The following is a description of a gene set: Catalysis of a biochemical reaction in which one of the substrates is a glycoprotein. studied in species Homo sapiens Human Gene Set: GOMF_CATALYTIC_ACTIVITY_ACTING_ON_A_GLYCOPROTEIN, and this is the list of marker genes: MGAT5B, MGAT5, MGAT3, FUT8, B3GNT3, C1GALT1C1, B4GALT7, MGAT2, GCNT4 (NCBI Gene Id 51301), B4GALNT3, GCNT1, MGAT4A, ABO, MGAT4C, POMGNT1, MGAT4B, B3GALT6, C1GALT1, MGAT1, C1GALT1C1L, GCNT3 (glucosaminyl (N-acetyl) transferase 3, mucin type), B3GNT6, B4GALNT4